Given this list of marker genes PTGIS, TJP1, ITGB2, PAK4, VEGFC, CXCL8, HSPB1 (heat shock protein family B (small) member 1), GAB1, FUT1, FGF18 (fibroblast growth factor 18), ANGPT2 (angiopoietin 2), CXCL12, NRP1, SEMA5A, TGFBR1, TERT, LRG1, FLT1, DSG2, MIR21, MIR29A, TGM2, EMILIN1, GRN, ADAM12, ANGPT4, MIR30B, PIK3R6, KDR, RAPGEF3, GDF2, JMJD8, CHRNA7, APELA, BMPER, AQP1 (NCBI Gene Id 358), MIR1908, AGGF1, MIR125A, STIM1, HYAL1, RUNX1, RLN2, MIR143, STAT3 (NCBI Gene Id 6774), HIPK1, TNN, SIRT6, CYBB, PKM, ADM2, HK2, SP1, SASH1, GATA2, HIF1A (hypoxia inducible factor 1 subunit alpha), CD34, ITGB8, DLL1, VASH2, WARS2, AGO2, SIRT1, PRKCA, MYDGF, RTN4, MIR130A, TLR3, MIR210, ISL1, PRKD1, DDAH1, PLCG1, MIR99B, TWIST1, TEK, ANGPTL3, RAMP2, ANXA3 (NCBI Gene Id 306), MIR132, XBP1, HIPK2, CXCR4, ITGB1, HMGA2, MIR378A, NR2E1, KLF4, MIR31, ERAP1, PDCL3, NOS3, MDK, GATA4, EPHA1, CCL11, C3AR1 (complement C3a receptor 1), WNK1, MIR20A, CMA1, TGFB1, ETS1, THBS1, WNT5A, MIR451A, NINJ1, SERPINE1, PIK3CD, MIR199A1, PDPK1, MTDH, TBXA2R, HMGB1, ENG, FGF1, TGFBR2, CX3CL1, EMILIN2, GHSR, ADM, PTK2B, APLNR, HMOX1, NTRK1 (NCBI Gene Id 7825), ITGA5, TMIGD2, CDH5, MIR30A, MIR27B, JUP, RRAS, ITGB3, ITGAX, MIR1224, SFRP2, C5AR1, SMAD1, F3, MIR126, IL1A, CYP1B1, CCR3, NFE2L2, CD40, HSPB6, CTNNB1, S100A1, GATA6, MIR199B, VEGFA, IL1B, C3, MIRLET7B, BRCA1, ZC3H12A, IL10, TNFSF12, MIR92A1, SPHK1, CLIC3, CXCR3, PDCD6, HTN1, PRKD2, CHI3L1, BTG1, PRKCB, JCAD, CCBE1, ECM1, FGF2, TIE1, AKT3, VEGFB, CCL24, MIR181B1, ZNF304, ABL1, CAMP, MIRLET7G, SMOC2, FOXC2, MIR1-1, EMP2, CELA1, JAK1, NODAL, RHOB, ACVRL1, ANGPTL4, EMC10, GREM1, GHRL, here is a description of the gene set: species: Homo sapiens Human Gene Set: GOBP_POSITIVE_REGULATION_OF_VASCULATURE_DEVELOPMENT Any process that activates or increases the frequency, rate or extent of vasculature development.